Given this list of marker genes DHCR24, NKG7, PMVK, MCM4, ACTA1, SUCLA2, RLN2, COMT, FHL2, PKM, COX6A1, MRPS27, CHAF1A, HSD17B10, CST7, LDHA, CDT1, SNAPC3, MYL6B, OIP5, TIAM1, UBA1, PLPP1, HMGN4, DFFA, PSMA5, FH, KIF2C, GINS1, HAUS7, EBP, ETFB, HPRT1, GSTA4, PSMD1, RAD1, UNG (uracil DNA glycosylase), ORC1, IGFBP4, NUTF2, DBI, MNAT1, SSRP1, PARP1, EIF3I, CDK1, CDC25C, SKAP2, SRD5A1, YWHAE, MKI67, CCT4, CSTB, SLC43A1, COX8A (cytochrome c oxidase subunit 8A), FADD, LAG3, CCDC6, CKS2, LTA4H, PHGDH, IZUMO4, FABP5, CPOX, ENO1, FSCN1, AP2S1, PPID, POLD2, KIFC1, MAPKAPK3, ECI1, NRAS, MAP2K3, PLP2, TOP2A, TMEM106C, BCL2A1, POLD3, CYB5B, PCCB, TRIP10, PCK2, VDAC3, CCNB1, OSGEP, RFC3, H2AX, TXLNA, LTBP4, METTL13, MYO1B, DNMT1, IDH2, ANXA5, SERPINE2, CCT6A, PGD (phosphogluconate dehydrogenase), MIF, FAH, NPM3, GZMH, PFAS, TPX2, STXBP2, DHFR, GALK2, BABAM2, WARS1, ATP1B3, ACTG1, LTA, HDGF, MCM5, AHCYL1, MRPL23, FPGT, TOMM40, MRE11, TRAP1, MARS1, TNFSF14, PLRG1, SIT1, HNRNPA3, STAMBP, MAT2A, HSP90AB1, HADH, CRYZ, ITGB3BP, RAD54L, GBP1, SORD (NCBI Gene Id 6652), MFSD10, PRDX1, ECHS1, NME1, BHLHE40 (basic helix-loop-helix family member e40), IL18R1, WDHD1, THOP1, NPC1, PEA15, PYCR1, IL1RN, AURKB, LGALS1, SNRPA, FRMD4B, PCLAF, SEC23IP, GGH, IMPA1, RTL8C, DUSP4, SLC25A5, TRAF1 (TNF receptor associated factor 1), DLGAP5, BCAT2, LMNB2, CDC45, HMGN2, TMPO, SRGAP2, PRIM1, BAG2, GK, EIF4A1, PDIA6, PCBD1, VCP, ATF1, CKAP5, NIPSNAP1, FANCI, SLC29A1, PTGIR, IGFBP2, ANXA2, CCNE1, STT3A, IPO5, FKBP2, CAMK1, ATP5MC1, LCP2, NEK2, ETHE1, GCLM, PSMC3, TTK, EEF1E1, S100A11, AIMP2, PSMA6, HNRNPA0, CIT, GGCT, CDC6, here is a description of the gene set: Genes down-regulated in follicular helper T cells: BCL6 high versus BCL6 low. from publication Kitano M, Moriyama S, Ando Y, Hikida M, Mori Y, Kurosaki T, Okada T (PMID 21636294) Human Gene Set: GSE24574_BCL6_HIGH_VS_LOW_TFH_CD4_TCELL_DN We found that a number of Tfh cells downmodulated BCL6 protein after their development, and we sought to compare the gene expression between BCL6-hi Tfh cells and BCL6-low Tfh cells. studied in species Homo sapiens